Given this list of marker genes RNFT2, WFS1, RNF185, CAV1, ATXN3, UBQLN1, BAG6, RNFT1 (ring finger protein, transmembrane 1), USP13, SGTA, TMX1, ATXN3L, UBQLN2, HERPUD1, XBP1, BCAP31, STUB1, NFE2L2, TMEM259, here is a description of the gene set: Human Gene Set: GOBP_POSITIVE_REGULATION_OF_ERAD_PATHWAY studied in species Homo sapiens Any process that activates or increases the frequency, rate or extent of ERAD pathway.